The following is a description of a gene set: Genes positively differentially expressed in cell type: CD4+ T cell upon treatment with cytokine: TNF-α in mouse lymph nodes in vivo. from publication Cui A, Huang T, Li S, Ma A, Pérez JL, Sander C, Keskin DB, Wu CJ, Fraenkel E, Hacohen N (PMID 38057668) Mouse Gene Set: CUI_T_CELL_CD4_TNFA_RESPONSE_UP Cytokines mediate cell-cell communication in the immune system and represent important therapeutic targets. A myriad of studies have highlighted their central role in immune function, yet we lack a global view of the cellular responses of each immune cell type to each cytokine. To address this gap, the authors created the Immune Dictionary, a compendium of single-cell transcriptomic profiles of more than 17 immune cell types in response to each of 86 cytokines (>1,400 cytokine-cell type combinations) in mouse lymph nodes in vivo. A cytokine-centric view of the dictionary revealed that most cytokines induce highly cell-type-specific responses. For example, the inflammatory cytokine interleukin-1β induces distinct gene programmes in almost every cell type. A cell-type-centric view of the dictionary identified more than 66 cytokine-driven cellular polarization states across immune cell types, including previously uncharacterized states such as an interleukin-18-induced polyfunctional natural killer cell state. species: Mus musculus, and this is the list of marker genes: Xaf1, Psma2, Ube2s, Il27ra, Cyb5a, Ltb, H2-K1 (histocompatibility 2, K1, K region), Ppa1, Zfp36l2, Birc3, Etv6, Bst2 (NCBI Gene Id 97478), Mvp, Fkbp5, Ndrg3, Psme1, Relb, H2-T23, Psmb8, Igfbp4 (NCBI Gene Id 26902), Samhd1, Mapkapk2, Il7r, Pgs1, Rrad, Tpm3, Myl12b, Tnfrsf18, Klhdc2, Bcl3, Tnfrsf4, Gramd2b, Ly6e, Tapbp, Kif1b, Sdf4, H2-T22, Batf, Isg15, Mndal, Ifit1, Stat1, Aars1, Isg20, Gbp2, Icam1, Bbc3 (NCBI Gene Id 170770), Psmb9, Nfkbia, Rtp4 (NCBI Gene Id 67775), Nars1, Zmiz2, Pik3ip1, Sema4a, Stat3, Serinc3, Tsc22d3, Vps28, Flot1, Sdhaf1, Dusp2, Apobec3, Cd47, Socs3, Chmp4b, Ssbp4, Cyba, Ly6a, Ogfr, Tcf7, Skap2, Rapgef6, Ctss, Zbp1, Rnf213, Ifi27l2a, Parp14, Nfkb2, Vars1, Ifi47, Iigp1, Cd82, Ikzf3, Ccnd3, Gbp7, Ddit4, Eif5a, Crlf2, Trim30a, Gltp, Gbp9, Gbp4, Huwe1, Irf7, Arid5b, Psme2, B2m, Eif2s2 (NCBI Gene Id 99435), Idnk, Tapbpl, Psmb10